Given this list of marker genes Hsd3b7, Osbpl1a, Osbpl3, Cyp27a1, Slc27a2, Akr1c21, Akr1d1, Acox2, Ncoa2, Acot8, Rxra, Cyp39a1, Ch25h, Osbpl2, Cyp8b1, Abcb11, Scp2, Osbp, Nr1h4, Hsd17b4, Osbpl7, Amacr, Akr1c20, Slc27a5, Osbpl6, Cyp46a1, Cyp7b1, Baat, Osbpl9, Cyp7a1, Akr1c6, Ncoa1, here is a description of the gene set: species: Mus musculus Synthesis of bile acids and bile salts Mouse Gene Set: REACTOME_SYNTHESIS_OF_BILE_ACIDS_AND_BILE_SALTS